Given this list of marker genes Pot1a, Blm, Recql4, Msh6, Pot1b, Mutyh, Ogg1, Rps3, Wrn, Msh2, Xrcc1, here is a description of the gene set: Binding to a DNA region containing an oxidized residue. Mouse Gene Set: GOMF_OXIDIZED_DNA_BINDING studied in species Mus musculus